Given this list of marker genes CNIH1, RNF130, DBNDD2, GFM2, APBB2, PPT2, CCDC47, HNRNPUL2 (heterogeneous nuclear ribonucleoprotein U like 2), KLHL20, TMLHE, EIF3L, PTPRS, UBE2J1 (NCBI Gene Id 51632), LRWD1, MYCBPAP, NCF2, CHODL, CAV2, GMFG, CARMIL1, ETFDH, UBQLN1, EXOSC10, C5orf24, MYLIP, TUFM (NCBI Gene Id 7284), ZNF146, IPO5, CTU1, MIA2, MARCO, FAM118B, TMEM63A, ARL8B, SASH3, CAMK1D, TFEC, UBE2A, STAG2, WNT11, HMGXB4, POM121, FOXJ2, REXO2, MBTPS1, HEATR6, PLIN3, FBXW11, CYP24A1, MAPK3, CYSLTR1, DESI2, PRNP, ORC2, ZSWIM7, DDX56, MAP3K7, KRT12, RGS10, PAICS, PRKD3, TUBGCP3, CPSF3, MAK16, ABR, SLC7A7, GPR84, THAP11, JADE1, MYO7A, LIMA1, FKBP15, EREG, OTUD6B, ALG5, ADAM9, LTC4S, C21orf91, SAA1, NFAM1, DOCK5, SMPDL3B, GSTZ1, RFC4, ATP2A2, PWP2, MLLT10, DYNLL1, TSPAN14, PGM2, DPH5, LTA4H, PSMG2, YIPF4, DHRS7B, SERF1A, OPN3, KCTD1, YWHAG, SLC7A6, UQCRC1, FADS1, PPBP, TACSTD2, CXCL6, GPR155, NOP56, UQCRB, C5orf34, F3, SIGLEC7, MAPK14, SASH1, CCT2, TMEM176B, CD9, PDF, MCFD2, AKAP9, CDH23, TARS1, ZMPSTE24, TLR2, NUDCD1, IMPDH2, ATL2, HHEX, H6PD, NFKBIZ, ATP6AP1, BECN1, ZDHHC12, SQLE, PKP2, COLGALT1, SLC4A8, QNG1, PLBD1, ZFP36L2, PON2, DHCR24, LIG3, SCAMP5, MRPL3, ACADM, PPARG, ATP6V0C, PSMD14 (proteasome 26S subunit, non-ATPase 14), NDRG3, DAPK1, SEPHS2, SREBF2 (sterol regulatory element binding transcription factor 2), HRAS, HID1, SALL3, GLRX, PRMT3, PIGO, DNASE1L1 (NCBI Gene Id 1774), PRKCH, BCCIP, YAF2, GABRA6, SOX4, IL36G, H2BC5, HDAC7, HERPUD1, TCEA2, PGLYRP1, XPO5, TARS2, STK17B, CXCL3, FPR1, PNO1, LMAN2, CPEB1, NOL11, DDX21, CEACAM21, IPO8, DIMT1 (NCBI Gene Id 27292), GARS1, ACSL5, MVD, IPO9, SLC30A5, TMEM106C, SLC39A9, ASXL1, DARS1, FRRS1, ACVR1B, PPCDC (phosphopantothenoylcysteine decarboxylase), INTS3, GJD2 (gap junction protein delta 2), TSPAN2, OXCT1 (NCBI Gene Id 7898), NUDCD2, here is a description of the gene set: Genes down-regulated in comparison of dendritic cells (DC) stimulated with LPS (TLR4 agonist) at 8 h versus DC cells stimulated with Gardiquimod (TLR7 agonist) at 8 h. from publication Amit I, Garber M, Chevrier N, Leite AP, Donner Y, Eisenhaure T, Guttman M, Grenier JK, Li W, Zuk O, Schubert LA, Birditt B, Shay T, Goren A, Zhang X, Smith Z, Deering R, McDonald RC, Cabili M, Bernstein BE, Rinn JL, Meissner A, Root DE, Hacohen N, Regev A (PMID 19729616) Human Gene Set: GSE17721_LPS_VS_GARDIQUIMOD_8H_BMDC_DN species: Homo sapiens mouse primary BMDCs were stimulated with tlr ligands and gene expression changes were profiled on Affymetrix arrays